Given this list of marker genes Psip1, Khdc4, Puf60, Setx, Celf2, Ythdc1, Srsf12, Luc7l3, Rbmx (NCBI Gene Id 19655), Srsf6, Prpf39, Celf1, Snrpc, Celf6, Sfswap, Ptbp2, Srsf10, Nol3, Celf4, Srsf1, Mbnl1, Celf5, Isy1, Slu7, Luc7l, Celf3, Luc7l2, here is a description of the gene set: Mouse Gene Set: GOBP_MRNA_SPLICE_SITE_RECOGNITION Selection of a splice site by components of the assembling spliceosome. studied in species Mus musculus